The following is a description of a gene set: The smaller of the two subunits of a mitochondrial ribosome. studied in species Mus musculus Mouse Gene Set: GOCC_MITOCHONDRIAL_SMALL_RIBOSOMAL_SUBUNIT, and this is the list of marker genes: Mrps21, Mrps22, Aurkaip1, Mrps27, Mrps31, Mrps17, Mrps25, Mrps24, Mrps28, Mrps23, Mrps16, Mrps18a, Mrps5, Dap3, Mrpl42, Mrps35, Mrps10, Mrps33, Mrps26, mt-Rnr1, Mrps34, Mrps18c, Mrps9, Mrps6, Ptcd3, Mrps7, Mrps14, Mrps18b, Mrps15, Chchd1, Mrps11, Mrps12, Mrps2